Given this list of marker genes LAP3, RNPEPL1, DPP9, PEPD, ACTMAP, MMP15, MMP17, KDM8, TPP2, AOPEP, MMP16, METAP1, DPP3, LVRN, ERAP1, ANPEP, LTA4H, ERAP2, DPP7, METAP2, METAP1D, MMP14 (NCBI Gene Id 4323), JMJD7, TRHDE (NCBI Gene Id 29953), XPNPEP2, NPEPPS (NCBI Gene Id 9520), DPP8, DNPEP, LNPEP, F11, NPEPPSP1, ENPEP, BLMH (bleomycin hydrolase), NAALADL1, RNPEP, DPP4, XPNPEP1, XPNPEP3, NPEPL1, CTSH, here is a description of the gene set: Human Gene Set: GOMF_AMINOPEPTIDASE_ACTIVITY Catalysis of the hydrolysis of a single N-terminal amino acid residue from a polypeptide chain. species: Homo sapiens